The following is a description of a gene set: Mouse Gene Set: GOMF_STRUCTURAL_CONSTITUENT_OF_MYELIN_SHEATH The action of a molecule that contributes to the structural integrity of the myelin sheath of a nerve. species: Mus musculus, and this is the list of marker genes: Gpm6b, Plp1, Mall, Mal, Pllp, Mobp, Marveld1, Cmtm8, Mbp, Ncmap, Mal2